Given this list of marker genes FOCAD, GPR35, PKHD1, APOB, GBA2, BCO1, EFL1, DNAJC21, TCF4, FARSB, MST1, SBDS, DZIP1L, CYP7A1, MTTP, SLC51B, SEMA4D, here is a description of the gene set: studied in species Homo sapiens Human Gene Set: HP_ABNORMAL_CIRCULATING_VITAMIN_A_CONCENTRATION Concentration of vitamin A in the blood circulation outside limits of normal. Abnormal circulating vitamin A concentration